Given this list of marker genes SRR, SERINC4, SDS, PSAT1, SDSL, PHGDH, SERINC1 (serine incorporator 1), SERINC2, SERINC3, SERINC5, PSPH, here is a description of the gene set: species: Homo sapiens Human Gene Set: REACTOME_SERINE_METABOLISM Serine metabolism